Given this list of marker genes Kcnq1, Kcnh7, Tgfbr2, Cox7b, Ndufc2, Acvr2b, Cybb, Pde4d, Kcnb1, Ifnlr1, Catsperz, Scn2a, Glra4, H2-Q2, Aph1c, Vps28, Snf8, Pigk, Ost4, Sec61b, Gjd4, Chrne, Cox7a2, Romo1, Atp5mg, Slc5a3, Cdh15, Grin2a, Fadd, Use1, Jup, Chrnb2, AA467197, Cdh19, Gabra1, Ugt3a1, mt-Atp8, Gja4, Vamp8, Vps37c, Cdh7, Uevld, Olfm2, Phb2 (prohibitin 2), Dab2, Cox4i1, Atp6v0d2, Ap5s1, Ap1s2, Gna13, Bet1, Uqcrb, Mfn1, Chrna1, Igf2r, Lrrc8a, Sdhd, Ubap1l, Gng3, Lrrc8d, Grik3, Itga11, Cox7a1, Abcg5 (ATP binding cassette subfamily G member 5), Traf3, Ighd, Ap2a2, Cacng6, Atp6v1g2, Gng12, Gng4, Apc2 (APC regulator of WNT signaling pathway 2), Kcnj14, Ighe, Pgm5, Calcrl, Ceacam1, Cd79a, Cacng5, Kcnh5, Lrrc38, H2-T22, Igf1r, Atp6v0a2, Pigu, Catsperd, Glrb, Cbl, Cdh6, Dnajc11, Dnm1, Ndufa12, Sun5, Ano2, Mlec, Atp6v0c, Gng2, Lrrc8b, Ndufb2, Pik3r5, Cyba, Cdh24, Flna, Magel2, Kcnma1, Copb1, Scnn1g, Itgb7, Micos10, Vamp4, Syk, Cdh9, Arl6ip1, Sestd1, Insr, Atp2a2, Cav2, Tap2, Vps11, Dmac2l, Vps33b, Shc1, Kcnq4, Gjb1, Itgb1, Atp6ap1l, Kcnmb1 (potassium large conductance calcium-activated channel, subfamily M, beta member 1), Igkc, Aak1, Ncstn, Fkbp1b, Snx12, Trpc3, Atp6v1b2, Tlr6, Calm2, Cdh20, Cacna2d3, Sec11c, Pyurf, Cacng3, Rac2, Tmed10, Sec11a, Ndufa10, Gpr89, Tomm5, Ndufb7, Kcnv2, Chrnb1, Psen1, Cftr, Duox2, Emc10, Necap2, Ap3m2, Itgad, Vps26a, Tpcn2, Sdha, Pkd1, Efcab7, S100a9 (S100 calcium binding protein A9 (calgranulin B)), Kcnh1, Bcl2, Chmp7, Vti1a, Pdia3, Elovl6, Scn11a, Rnf125, Cacna2d4, Copg1, Atp6v1h, Pigt, Grik5, Vps33a, Ndufa2, Cacna1h, Dag1, Sar1a, Gnb1, Synj1, Vwc2l, Gng10, Cope, Cdh5, Dtna, Gria1, Hsd17b12, Atp6v0e2, Cacna1f, Ap1m1, Chrna10 (cholinergic receptor, nicotinic, alpha polypeptide 10), Glra1 (glycine receptor, alpha 1 subunit), Fxyd2, Gng5c, Utrn, Cdh26, Cd3g, Gjb3, Syne1, Ccdc51, Ap5z1, Sec61a2, Gjd2, Gosr2, Gnat3, Trpc6, Atp6v1e1, Slc1a3, Tfrc (NCBI Gene Id 76361), Gosr1, Trpc7, H2-M10.3, Ndufb4, Tomm22, Arcn1, Tlr2, Fzd8, Clic5, Copa, Trdn, Traf5, Trpc1, Atp6-ps, Ndufs6b, Ttyh3, Atp5f1d, Trmt10b, Il18r1, Iglc1, Bet1l (NCBI Gene Id 80411), Chmp1b2, Grid2, Ndufv2, Cachd1, Insrr, Htr3b, C8g, Scn9a, Catspere1, Kcnj13, Ndufa9, Sec13, Uqcrfs1 (ubiquinol-cytochrome c reductase, Rieske iron-sulfur polypeptide 1), Dennd5a, Emc8, Sgcd, Wnt9b, Ern2, Itgb4 (NCBI Gene Id 217330), Gria2, Tmed10-ps, Ap2b1, Stx1a, Pigyl, Vps18, Kcng1, Alg14, Syne4, Kcnh3, Hc, Becn2, Epn2, Gria4, Timm10, Nox1, Kcnk7, Cngb1, Copb2, Lamtor2, Ptpa, Pik3r3, Atp6v1c2 (NCBI Gene Id 68775), Kcnv1, Sclt1, Sgip1, Kcna10, Kcnd1, Mfsd8, Cflar, Erbb3, Hspd1, Tomm7, Gjb4, Tlr1, Tcirg1, Kcnj10, Ctnnb1, Atp1a4, Il12rb1, Ap1s3, Dctn1, Gnb3, Slc6a3, Clmn, Cox6b2, Amfr, Sun3, Kcna4, Chrnd, Micu1, Dlg1, Kcna2, Gjb2, Emc2, Csf2ra, Ncf2, Cox5b, Stt3b, Kcnq2, Gnat1, Kcnip1, Hspa2, Dnajc15, Olfm3, Timm21, Hcn2, H2-M5, Ankfy1, Diablo, Tapbp, Slc9a1, Srpra, Snx3, Scap, Kcna3, Kcng4, Gnaq, Anxa2, Ndufs3, Copz1 (coatomer protein complex, subunit zeta 1), Mtx2, Sntb1, Ndufs1, Vps35, Dennd4c, Clcn2, Pigp, H2-T10, Gabbr1, Cttn, H2-T3, Gngt2, Ap3s2, Alcam, Pik3r2, Napb, Shisa7 (shisa family member 7), H2-K1, mt-Co1, S100a10, Trex1, Apoo, Kcns1, Sar1b, Grpel2, Best1, Kash5, Slc6a6, Dlg2, Map3k5, Cacna1d, Gng5, Tusc3, Ap2m1, Afg2b, Kcna1, Atp5po, Arl6, Pira2, H2-DMa, Casp8, Ndufab1, Rpn2, Best2, Syne2, Mtx1, Itgal, Tfr2, Vdac1, Cd14, Ramp1, Kcnj3, Itgb3, Stx18, Itga2b, Akap9, Scn1b, Fam8a1, Tmed3, Ap1g2 (adaptor protein complex AP-1, gamma 2 subunit), Scn2b (NCBI Gene Id 72821), Snx27, Chrnb3, Uqcrh, Snx2, Slc18a3, Ndufs5, Pkd2l1, Il23r, Stx11, Lrrc8c, Ndufs7, Kcnk1, Kcnb2, Scn1a, H2-Ea, Clba1, Emc4, Il6, Timm23, Cacna2d2, Tmem199, Kcnq3, Atp1a1, Gnb2, Scn3a, Sec23a, Calm3, Gpr156, C8a, Cox4i2, Spaar, mt-Nd2, Ndufb6, Crb1, Cacna2d1, Dpm2, Cdh11, Atp1b3, Trpc5, H2-DMb2, Sntg2, Pik3cb, Stxbp5l, Ap4m1, mt-Atp6, Kcns2, Mpp7, Immp2l, Chrna4, Sec31a, Snx4, Scnn1b, Immt, Atg5lrt, Cnih2, Pmp22, Kcnab1, Atp6v1d, Syne3, Vps29, Atp5f1e, Itgb6 (integrin beta 6), Gjc2, Itga4, Uqcrc2, Calr, Ugt3a2, mt-Nd1, Atp1a2, Kcnj1, Cntnap2, Cdh22, Adam8, Becn1, Lamtor5, Inha, mt-Nd3, Syvn1, Gp9, Gja3, Napg, Gabra5, Cdh13, Slc1a2, Ctdnep1, Aph1a, Cntfr, Rnasek, C7, Sacm1l, Ostc, Necap1, Grin2b, Clta, Pigq, Chchd10, Catspere2, Mep1b, Kcne4, Piga, Enthd1, Gnas, Tap1, Ripk1, Itgb2l, Ston1, Stx2, Uvrag, Hcn4, Ap2s1, Uqcc3, Aph1b, Ap3b1, Foxred1, Catsper1, Gabrb1, Atp1a3, Gja10, Trac, Gabrb3, Vps37d, Gng7, Trat1, Sec31b, Pkd2 (NCBI Gene Id 77380), Cox8c, Bmp2, Bax, Cdh3, Gabrr2, Cnga4, Dad1, Ubxn7, Immp1l, Uqcr10, Smdt1, Ap1b1, Kcnip2, Wnt3a, Ap4s1, Calcr, Kcng3, Samm50, Fxyd1, Afg3l2, Lamtor4, Catsperg2, Catsperb, Ndufb5, Spcs3, Lrp6, Cacnb1, Calm1, Lamtor1, Vinac1, Scyl1, Abhd12, Afdn, Slc17a8, Hook3, Emc6, Micu2, Snap47, H2-T23, Gja6, Gabrq, Rhag, Fkbp1a, Psenen, Porcn, Tbc1d5, Gria3, Kcnc1, Ern1, Ndufa5, Atp6v0b, Slc4a1, Ly96, Cdh1, Ndufa4l2, Itgav, Grpel1, Il18rap, Napa, Spg7, Lilra6, Ap4b1, Sec24d, Cd247, Gja1, Krtcap2, Tomm40l, H2-Q4, Itgb8, Dchs1, Nalcn, Ubap1, Uqcrc1, Tlr4, Sting1, H2-M10.4, Mep1a, Chrna9, Hfe, Prkca, Jak2, Vps26b, Cd34, Pik3cg, Slc3a2, Drd2, Abhd6, Timm44, Acvr1c, Ndufa3, Ap2a1, Itga6, Gna11, Ap1m2, Sec24c, Mvb12a, Chrna7, Ap4e1, Uqcrh-ps1, Kcnj8, Timm22, Timm50, Kcnc2, Kcnh2, Chrna2, Ncf1, Ap1g1, Glra2, Khdrbs1, Csf2rb2, Insig1, Efcab9 (NCBI Gene Id 73944), Afg3l1, Cdh23, Cox7a2l, H2-M10.5, H2-M2, Itga9, Alg13, Clcc1, Mtx3, Kcnk13, Ndufb1, Kcna7, Pik3cd, Ndufv3 (NADH:ubiquinone oxidoreductase core subunit V3), Clic4, Crb2, Igf1, Slc25a4, Cox7b2, Snap91, Ramp3, Erbb2, Kcnd2, Dmd, Cacnb4, Kcnj2, Snap23, Clic3, Hmgb1, Duox1, Itgae, Sec24a, Lrrc52, Chmp1a, Kcnu1 (NCBI Gene Id 16532), Krt8, Cacna1c, Mmgt2, Eps8, Sun1, Ndufb4b, Cav3, Kcnab3, Tmem109, Micos13, Gna15, Atp1b4, Ap3b2, Kcnk4, Nrbf2, Cd74, Stx5a, Birc2, Gng14, Atp5mc2, Ndufab1-ps, Ret, Ptpn6, Aftph, Kcng2, Chuk, Kcnj16, Pira12, Kcnd3, Ndufs4, Grin1, Ano6, Trpc2, Gnat2, Sec22b, Gabbr2, Grik2, Ctnna1, Ndufs6, Fcgr4, H2-M10.6, Cnga1, Insig2, Sec61a1, Dipk2a, Chmp2b, Coro1c, Stx6, Cplx4, Stx7, Abcg8, Shisa6, Ndufa8, Cldn4, Chchd6, Gp1bb, Ptk2b, Pik3c3, Lyn, Lamp2, Itga8, Cideb, Pdss2, Cpt1c, Lin7b, Tomm20l, Kcnj6, Atp5mj, Gabrg1, Ank1, Grik4, Dpp6, Rnf139, Sdhc, Catsper4, Picalm, Hcn3, Nherf1, Cnep1r1, Dpp10, Ndufa11, Cav1, Lrrn3, Abcc8, Pex5l, Iqce, Gabrd, Stac3, Snx8, Pef1, Ssr4, Kcnj9, mt-Nd5, Stxbp5, Pik3r4, Hook1, Kcna6, Vcam1, Pik3r1, Tmem37, Nrn1, Itgb2, Kcnj15, Lrrc26, Atp6v0a1, Chmp2a, Itga1, Cdh10, Sspn, Tomm6, Gjb6, Vti1b, Sgcz, Gnai2, H2-Q1, Syn2, Ext2, Slc25a31, Kcna5, Ap3s1, Cacna1g, Ikbkb, Gpaa1, Scn10a (NCBI Gene Id 208230), Vwc2, Ostm1, H2-Eb1, Lin7a, Slco6c1, Dmac2, Itga5, Gabra3, Scn5a, Ms4a2, Gabrb2, Pik3ca, Ighm, Atp1b2, Cltc, Ndufc1, C2cd6, H2-DMb1, Sgcg, H13, Cacng2, Sec61g, Kcnc3, Unc80, Sdhb, Cacng8, Fxyd4, mt-Nd4l, Catsper2 (cation channel, sperm associated 2), Clic1, Stx1b, Vamp1, Kcnmb2, Kcne2, Ndufa11b, Atp6ap1, Kcnj12, Agk, Gnai1, Snx1 (sorting nexin 1), Atp5f1c, H2-Aa, Kcnip3, Itgam, Timm17a, Arxes2, H2-M10.1, Cox8b, Gnb5, Pigh, Csf2rb, Cacng4, Gnb4, Slc7a5, Itga10, Trbc2, Stx12, H2-Eb2, Ykt6 (NCBI Gene Id 80527), Ndufb9, Rp9, Htra2, Dmac1, Hcn1, Ryr3, Nploc4, Ndufa7, Faf2, Pigc, Cd40, Lrrtm4, Atp4b (ATPase, H+/K+ exchanging, beta polypeptide), Chmp6, Cdh2, Cacnb2, Cacna1e, Bak1, Tapbpl, Ryr2, Flot2, Derl1, Tyk2, Kcnmb3, Copz2, H2-Q6 (histocompatibility 2, Q region locus 6), Cnga3, Cyc1, Faf1, Mvb12b, Rab7, Timm9 (translocase of inner mitochondrial membrane 9), Sun2, H2-Ab1, Vps37b, Itga2, Trpm5, Gabrp, Cngb3, H2-M11, Sntg1, Clint1, Hvcn1, Ap3d1, Slc25a5, Chrna5, Spcs2, Timm29, Hook2, Snta1, Krt19, Pam16, Atp5pd, Ctnnd1, Abcb8, Cnga2 (NCBI Gene Id 27312), Scn4a, Stx19 (syntaxin 19), Stx17, C9, Atp6v1b1, Slc38a9, Atp6v1f, H2-Q7, Gp1ba, Apool, Noxa1, Pln, Ttyh2 (NCBI Gene Id 68535), Ppif, Chrng, Emc3 (NCBI Gene Id 66087), Doc2b, Ctnna2, Htr3a, mt-Co2, Kcnj5, Tomm40, Atp6v1g3, Ubxn1, Atp6ap2, Atg14, Ryr1, Chrna3, Atp6v0a4, Gna12, Chrnb4 (cholinergic receptor, nicotinic, beta polypeptide 4), Chmp1b, Epn3, C8b, Gabrg2, Atp5f1a, Olfm1, Snap25 (synaptosomal-associated protein 25), Cltb, Acvr1b, H2-Oa, H2-M9, Tspan32, Uqcr11, Sorbs1, Ndufv1, Atp4a, Sdcbp, Gna14, Zap70, Spag4, Ahnak, Tpcn1, Ifnl2, Gng11, Cdh18, Clcnka, Lrg1, Tepsin, Ap5b1, Atp6v1a, mt-Cytb, Noxo1, Apbb1ip, B2m, Clcnkb, Cacna1s, Itgb5, Timm10b, Srebf2, Il6ra, Emc7, Gja8, Btbd8, Kcns3, Ndufb8, Kcnip4, Tmem249, Grin3b, Kcne5, Synrg, Gng8, Grm1, Gjc1, Ano1, Vamp9, Atp6v1g1 (NCBI Gene Id 98834), Scn8a, Clic6, Stx3, Grb2, Lrrc55, Cox5a, Casp3, Gypa, Cox7c, Akap6, Hjv, Psen2, Il6st, Shisa8, Itgax, Cacna1a, Fcer1g, Vps16, H2-Ob, Ndufaf2, Tsg101, Slc1a6, H2-M3, Ndufa6, Ramp2, Trbv19, Scnn1a, Klhl12, Trpv6, Selenos, Atp1b1, Vps25, Kcnj11, Timm17b, Gjb5, Pdss1, Ddost, Kcnab2, Patj, Cd3d, Ndufa13, Ifnl3, Trf, Wdr93 (NCBI Gene Id 626359), Pkd1l3, Lime1, Snx5, Plekha7, Kcnj4, Sgcb, Epn1, Chrna6 (cholinergic receptor, nicotinic, alpha polypeptide 6), Grin2d, Stt3a, Micu3, Magt1, Stx4a, Lin7c, Tgfbr1, Kcnk2, Aqp1, Emc1, Tspan33, Catsperg1, Srprb, Cldn17, Dlg4, Mcub, Grid1 (NCBI Gene Id 14803), Grin3a, Cdh4, Ndufb4c, Sec63, Sgca, Arxes1, Ufd1, Chmp3, mt-Co3, Rpn1, Ticam2, Trbc1, Mmgt1, Flot1, Gabra4, Gjc3, Cplx3, Atp5pf, Slc26a6, Ndufa4, Drd1, Sgce, Ncf4, H2-Q10, Ttyh1, Ndufs8, Gng13, Scn4b, Vps36, Snap29, Vdac2, Plp1, Lrrc8e, Atp6v1e2, Epb42, Cdhr18 (NCBI Gene Id 238939), Trpm4, Sumo1, Pik3r6, Dlg3, Vamp2, Pira13, Gjd3, Neo1, H2-M1, Kcne3, H2-M10.2, Ceacam2, mt-Nd4, Atp5mc3, Acvrl1, Gp5, H2-D1, Vdac3, Tmem262, Tmem258, Kcnf1, Chchd3, Best3, Gfra1, Eps15, Abcc9, Vamp3, Slc17a7, Atp5pb, Vps8, Aktip, Osmr, Atp5mc1, Snx6, Tnk2, Csf2, Chmp4b, Sec24b, Evc, Cox8a, Gnaz, Sel1l, Pigs, Cdh8, Pomt1, Ndufa1, Baiap2l2, Vps37a, Ndufb3, Lamtor3, Itga7, Fas, Ndufb10, Kcne1, Cox6c, Clcn1, Gnal, Chmp4c, Gngt1, Atp5f1b, Cox6c2, Gja5, Eps15l1, Crb3, Vps39, Gnao1, Ndufb11, Trpc4, Rnf31, Emc9, Copg2, Cacna1b, Mr1, Gnai3, Entr1, Trav18, Atp6v0e, Pkd1l1, Apc, Gabrr1, Rhd, Gabra6, Kcnq5, Atp6v0d1, Bloc1s6 (NCBI Gene Id 56387), Vcp (valosin containing protein), Cox6a1, Atp5me, Sntb2, Trim27 (NCBI Gene Id 19720), Tril, Ndufs2, Ccdc115, C6, Nox3, Irs1, Cplx1, Grin2c, Cox6b1, Ston2, Cd6, Itga3, Kcnc4, Cdh17 (cadherin 17), Ap3m1, Pacc1, Traf6, Phb1, Skap1, Bnip1, Trpv5, Uqcrq, Cplx2, Atp6v1c1, Acvr1, mt-Nd6, Cnih3, Evc2, Grik1, Cacng7, Cox6a2, Dnajc19, Cd3e, Gabra2, Cdh12, Ap1s1, Amigo1, Kcnh8, Clcn7, Pdcd6, Atp5mk, Slc17a6, Emilin1, Kcnmb4, Atp5mf, Sec23b, Ap5m1, Cd79b, Acvr2a, Gje1, Ndufb11b, Tgfbr3, Shisa9, Tomm20, Adam10, Cacng1, Nox4, Glra3, Itgbl1 (integrin, beta-like 1), Mcu, Diaph3, Cacna1i, Catsper3, Cacnb3, Stx16, Mpdz, Scn3b, Vps41, Vac14, Pdzd11, Spcs1, Traf2, Gabrg3, Stx8, here is a description of the gene set: Any protein complex that is part of a membrane. species: Mus musculus Mouse Gene Set: GOCC_MEMBRANE_PROTEIN_COMPLEX